The following is a description of a gene set: Mouse Gene Set: GOBP_LUNG_GOBLET_CELL_DIFFERENTIATION The process in which a relatively unspecialized cell acquires specialized features of a lung goblet cell. A goblet cell is a cell of the epithelial lining that produces and secretes mucins. studied in species Mus musculus, and this is the list of marker genes: Foxp1, Foxp4, Hoxa5, Spdef, Agr2